The following is a description of a gene set: The directed movement of a protein to a specific location on a chromosome. species: Homo sapiens Human Gene Set: GOBP_ESTABLISHMENT_OF_PROTEIN_LOCALIZATION_TO_CHROMOSOME, and this is the list of marker genes: ACD, SPDYA, NABP2 (NCBI Gene Id 79035), H1-5, TCP1, CCT6A, POT1, WBP2, USP7, CTCFL, SGF29, NIPBL, WRAP53, TERT, RUVBL2, MACROH2A1, SPIDR, TERF1 (NCBI Gene Id 7013), ZNF827, BRCA2, MACROH2A2, LRWD1